Given this list of marker genes Zic3, Pkd2, Nphp3, Dnaaf1, Ccdc39, Ccdc40, here is a description of the gene set: species: Mus musculus Mouse Gene Set: GOBP_DETERMINATION_OF_LIVER_LEFT_RIGHT_ASYMMETRY Determination of the asymmetric location of the liver with respect to the left and right halves of the organism.